Given this list of marker genes Nat8l, Phgdh, Gnmt, Aspa, Got1, Aasdhppt, Bhmt, Aass, Ass1, Slc38a8, Aspg, Dlst, Mat1a, Gcat, Asns, Adss2, Tha1, Adi1, Mtap, Plod3, Enoph1, Mtrr, Apip, Tdh, Mtr (NCBI Gene Id 99131), Mthfd2l, Asnsd1, Nit2, Asrgl1 (NCBI Gene Id 66514), Plod2, Thnsl2, Got1l1, Got2, Bhmt2, Mthfr, Adss1, Aadat, Pipox, Atf4 (activating transcription factor 4), Mri1, Ddo, Bhmt1b, Mthfd1, here is a description of the gene set: Mouse Gene Set: GOBP_ASPARTATE_FAMILY_AMINO_ACID_METABOLIC_PROCESS The chemical reactions and pathways involving amino acids of the aspartate family, comprising asparagine, aspartate, lysine, methionine and threonine. studied in species Mus musculus